The following is a description of a gene set: Mouse Gene Set: GOBP_EXTRACELLULAR_STRUCTURE_ORGANIZATION studied in species Mus musculus A process that is carried out at the cellular level which results in the assembly, arrangement of constituent parts, or disassembly of structures in the space external to the outermost structure of a cell. For cells without external protective or external encapsulating structures this refers to space outside of the plasma membrane, and also covers the host cell environment outside an intracellular parasite., and this is the list of marker genes: Col5a3, Impg2, Fktn, Rxfp1, Mkx, Col11a2, Vps33b, Mmp10, Smoc2, Bcl3, Apbb2, Loxl4, Eln, Otol1, Elf3, Col13a1, Col7a1, Mmp17, Has3, Cflar, Itih1, Mmp11, Mmp27, Reck, Plod3, Loxl2, Nox1, Apbb1, Ercc2 (excision repair cross-complementing rodent repair deficiency, complementation group 2), Antxr1, Aebp1, Plod2, Adamts8, Egflam, Col9a1, Adamts7, Col6a1, Tnr, Col28a1, Ihh, Mia, Adamts6, Phldb2, Tgfb1, Adamts3, Aplp1, Myo1e, Mmp21, Ptk2, Col6a5, Smoc1, Col4a5, Col1a1, Plg, Prdx4, Anxa2, Nepn, Axin2, Col6a4, Tnf, Dnajb6, Cav1, Foxc2, Adamts1, Vit, Col27a1, Adamts12, Mpv17, Mfap4, Adamts13, Csgalnact1, Mpzl3, Cma1, Cyp2j6, Cpb2, Clasp1 (CLIP associating protein 1), Tmem38b, Col10a1, Slc2a10, P3h1, Notch1, Matn3, Ccn2, Mmp24, Colq, Adamts4, Cst3 (cystatin C), Ric1, Nfkb2, Klk5, Gfap, Ndnf (neuron-derived neurotrophic factor), Comp, Lox, App, Kif9, Col9a3, Chadl, Col8a1, Lama2, Foxf1, Col6a6, Ero1b, Pomt2, Col4a1, Ntn4, Foxc1, Ltbp4, Col4a2, Pparg, Nphp3, Smarca4, Postn, Hspg2, Ccdc80, Smad3, Wt1, Carmil2, Ddr1, Scx, Myh11, Hsd17b12, Rgcc, Efemp2, Prdm5, Adamts15, Idua, Slc39a8, Ambn, Olfml2a, Gfod2, Hmcn1, Nphs1, Ctsg, Tfap2a, Spint1, Hpn, Thsd4, Nr2e1, Creb3l1, Eng, Col5a2, Atp7a, Col23a1, Exoc8, Tnxb, Colgalt1, Bmp2, Mmp23, Tgfbi, Col22a1, Myf5, Adamts5, Grem1, Dmp1, Abl1, Hpse2, Emilin1, Tie1, Adamts10, Ext1, Egfl6, Col16a1, Noxo1, Ccn1, Adamtsl2, Pmp22, Ier3ip1, Col2a1, Ero1a, Col11a1, Aplp2, Scara3, Tgfbr1, Foxf2 (forkhead box F2), Col9a2, Dpp4, Il6, Matn2, Mmp12, Lamc1, Meltf, Itga8, Selenon, Tcf15, Adamts18, Marco, Papln, Mia3, Flot1, Agt, Mansc4, Mmp3 (matrix metallopeptidase 3), Mmp7, Ibsp, Pomgnt1, Tnfrsf1b, Dpt, Impg1 (interphotoreceptor matrix proteoglycan 1), Mmp15, Mmp19, Arhgap33os, Fgfr4, Smad4, Nid1, Prickle1, Tex14, Antxr2, Lamb3, Wnt3a, Col1a2, Fbln5, Large1, Flrt2, Serpinf2, Adamtsl4, Tfip11 (NCBI Gene Id 54723), Col4a3, Crispld2 (NCBI Gene Id 78892), Acan, Gas6, Col15a1, Fbln1, Gpm6b, Adamts14, Sfrp2, Mmp16, Gas2, Rb1, Lcp1, Itgb3, Npnt, Dag1, Tgfbr3, Phldb1, Optc, Serac1, Vtn, Serpinb5, Has1, Hapln2, Smpd3 (sphingomyelin phosphodiesterase 3, neutral), P4ha1, Ecm2, Pomt1, Itgb1, Ctss, Plod1, Has2, Sox9, Zfp469, Col24a1, Cyp1b1, Col4a4, Angptl7, Fap, Col4a6, Abl2, Fkbp10, Adamts20, Adtrp, Mmp1a, Adamts16, Clasp2, Mmp20, Pdpn, Fermt1, Crtap, Fshr, Mmp2, Matn1, Nf1, Mmp8, Megf9, Fn1, Ddr2 (discoidin domain receptor family, member 2), Vhl, Sh3pxd2b, Mmp1b, Lamb2, Pbxip1, Pxdn, Lmx1b, Adamts2, Col8a2, Ramp2, Spint2, Lemd3, Pdgfra, Lamb1, Dspp, 2300002M23Rik (NCBI Gene Id 69542), Col18a1, Mmp9 (matrix metallopeptidase 9), Qsox1, Mad2l2, Loxl3, Tnfrsf11b, Tnfrsf1a, Mmp13, Col3a1, Ets1, Cav2 (caveolin 2), Fkrp, Spock2, P3h4, Mmp28, B4galt1, Lama1, Col17a1, Ric8a, Loxl1, Adamts19, Adamts9, Olfml2b, Adamts17, Vwa1 (NCBI Gene Id 330009), Mmp25, Col19a1, Klk4, Fscn1, Lgals3, Vipas39, Col5a1, P4ha3, Abi3bp, Ptx3, Kazald1, Mmp14, Atxn1l, Sema5a, Wdr72, Tgfb2, Serpinh1, Sulf2, Col14a1, Matn4, Sulf1, Adamtsl1